The following is a description of a gene set: Human Gene Set: GOBP_POST_TRANSLATIONAL_PROTEIN_TARGETING_TO_MEMBRANE_TRANSLOCATION studied in species Homo sapiens The process in which a protein translocates through the ER membrane posttranslationally., and this is the list of marker genes: SEC63, SEC61A2 (SEC61 translocon subunit alpha 2), SEC61A1, SEC62, HSPA5, GLP1R, SEC61B, SEC61G